The following is a description of a gene set: Protection of epithelial surfaces of the gastrointestinal tract from proteolytic and caustic digestive agents. species: Mus musculus Mouse Gene Set: GOBP_MAINTENANCE_OF_GASTROINTESTINAL_EPITHELIUM, and this is the list of marker genes: Htr4, Slc22a21, Inava, Tlr9, Pbld2, Nod2, Zfp830, Tff2, Vsig1, Neurod1, Pbld1, Rbp4, Slc22a5, Tff1, Strap, Tlr4, Muc4, Muc2, Sox9, Il10ra, Muc13, Tff3, Il17a, Cracd